The following is a description of a gene set: species: Homo sapiens Human Gene Set: GOBP_CELL_MIGRATION_INVOLVED_IN_GASTRULATION The migration of individual cells within the blastocyst to help establish the multi-layered body plan of the organism (gastrulation). For example, the migration of cells from the surface to the interior of the embryo (ingression)., and this is the list of marker genes: CER1, FGF8, NODAL, NCKAP1, MIXL1, APELA, CRB2, SOX17, AMOT, GPC3, LRP5, RIC8A, MEGF8, EPB41L5